The following is a description of a gene set: A process leading to the generation of a functional piRNA. piRNAs (Piwi-associated RNAs) are a class of 24- to 30-nucleotide RNAs derived from repeat or complex DNA sequence elements and processed by a Dicer-independent mechanism. studied in species Homo sapiens Human Gene Set: GOBP_PIRNA_PROCESSING, and this is the list of marker genes: TDRD6, PNLDC1, MOV10L1 (NCBI Gene Id 54456), TDRD12, TDRD1, TDRD9, GPAT2, MAEL, EXD1, PIWIL4, PLD6, DDX4, PIWIL2, TDRD7, FBXO24, TEX15, PIWIL1, TDRKH, GTSF1, HENMT1, FKBP6, PIWIL3